Given this list of marker genes KRT14, KRT5, SASH1, IFNG, TSC2, DNAJC21, POFUT1, TSC1, here is a description of the gene set: Human Gene Set: HP_HYPOMELANOTIC_MACULE Hypomelanotic macule species: Homo sapiens Hypomelanotic macules (\ash leaf spots\) are white or lighter patches of skin that may appear anywhere on the body and are caused by a lack of melanin. White ash leaf-shaped macules are considered to be characteristic of tuberous sclerosis.